The following is a description of a gene set: studied in species Homo sapiens Downregulation of SMAD2/3:SMAD4 transcriptional activity Human Gene Set: REACTOME_DOWNREGULATION_OF_SMAD2_3_SMAD4_TRANSCRIPTIONAL_ACTIVITY, and this is the list of marker genes: SNW1, SKIL, SMAD7, UBE2D1, UBB, SMAD4, RPS27A, NCOR2, ATP1B4, TGIF2, PARP1, TGIF1, NEDD4L, WWTR1, RNF111, USP9X, UBE2D3, NCOR1, MAPK3, TRIM33, SMURF2, UBA52, MAPK1, UBC, SERPINE1, STAT1, SMAD3, SMAD2, SKI, PPM1A, HDAC1